The following is a description of a gene set: Human Gene Set: REACTOME_SIGNALING_BY_SCF_KIT Signaling by SCF-KIT studied in species Homo sapiens, and this is the list of marker genes: PTPN6, YES1, PIK3R3, STAT5A, VAV1, STAT1, LYN, LCK, SOCS1, GRB10, FYN, CBL, KRAS, KIT, TEC, SH2B3, PTPRU, STAT3, MMP9, GRAP, CMA1, CHEK1, PIK3R2, GAB2, SOCS6, SRC, SOS1, PRKCA, FER, KITLG, JAK2, HRAS, GRAP2, STAT5B (NCBI Gene Id 6777), PTPN11, PIK3R1, NRAS, PIK3CA, FES (NCBI Gene Id 2242), RAC1, GRB2, SH2B2, GRB7